The following is a description of a gene set: species: Homo sapiens Genes in the cancer module 372. Human Gene Set: MODULE_372, and this is the list of marker genes: LARS1, POLA1, SOX8, KIF11, FEN1, NUP50 (nucleoporin 50), RBM14, COLEC11, CCNJ, ATAD2, MSH2, RNF123, FOXP2, RCOR3, NPR1, ECT2, ADAMTS13, CCNE2, DLEU1, ABCC4, SLC26A2, HEXA-AS1, TWSG1, KLHL2